The following is a description of a gene set: from publication Chen Y, Wang X (PMID 31504780) species: Homo sapiens Human Gene Set: MIR378A_3P_MIR378C_MIR378D_MIR378I Genes predicted to be targets of miRBase v22 microRNA hsa-miR-378a-3p, hsa-miR-378c, hsa-miR-378d, hsa-miR-378i in miRDB v6.0 with MirTarget v4 prediction scores > 80 (high confidence targets)., and this is the list of marker genes: CHAMP1, ELAC1, KLK4, RAN, NKX3-1, C4orf46, AK7, UHRF1, KCNIP2, METTL4, ZNF124, SULF1, GPR156, RNF168, ZFPM2, CPD, PROK2, RPN2, TSPAN17, AGK, FLT1, VPS53, PTGES3, PHC3, RAB10, IQSEC1, NUAK2, NPAS4, OTUB2, CCNI2 (cyclin I family member 2), WDR64, JADE3, NCAPG, CREBRF, FCGR1A, ATXN7L3B, RP1L1, NR2C2, PLCXD2, PIM2, NHSL3